Given this list of marker genes CBFA2T3, KCNE2 (NCBI Gene Id 9992), IL1B, NRDC, RACK1, MBP (NCBI Gene Id 4155), CSNK1E, PACSIN3, FADD, CYFIP2, ELOB, ASTL, RNF185, NKD2, FBXW8, PAQR3, DAB2, WFS1, BAG2, NUPR1, CLN6, FURIN, CDC20, GRN, DDA1, SIRT1, PLK1, SH3RF3, RCN3, SH3RF2, PABIR1, FBXW11, PSMC6, HSPA1A, PRICKLE1, VCP, CDK5RAP3, RHBDD1, SH3RF1, MDM2, IST1, PSMD10, F12, BAK1, ATP5IF1, DDRGK1, APP, FMR1, UBQLN2, TGFB1I1, LAPTM5, SEMG2, ATXN3, PSMC3, L3MBTL3, ASPH, ANGPTL8, AXIN2, HSPBP1, NFE2L2, TMTC3, SMAD7, SUMO2, MAPK9, SOCS5 (NCBI Gene Id 9655), UFL1, GBA1, TRIB1, PIAS1, CFL1, FBXO22, KLKB1, TRIM67, DET1, USP5, IL33, RFPL1, STUB1, RNF180, PRSS22, ECSCR, ZYG11B, TNP2, PSMC4, CLU, CAV1, ADRA2A, MYH9, HSPA1B, CASP8, TNFRSF1B, AURKA, TMX1, FBXW7, DISC1, PSMC1, SMURF1, PTEN, RNFT1, TMEM259, SOCS4, NUB1, RNFT2, RBX1, AKT1, PLGRKT, CSNK1D, XBP1, UBQLN1, SUMO1, FZR1, SH3D19, DVL1, MTOR, SRC, PLK3, BBS7 (Bardet-Biedl syndrome 7), HAMP, PSENEN, CEBPA, TNF, KLHL40, VSIR, PSMC2 (proteasome 26S subunit, ATPase 2), RNF139, CTSC, TBC1D10A, OGT, CAV3, USP13, ENO1, SPON1, SERPINB3, GABARAP, ANXA2, RCHY1, ADAM8, MELTF, AURKAIP1, PSMC5, TRIM32, PYHIN1, FGFR4, PRKN, IFNG, RGMA, TANK, BAG6, AXIN1, HPN, LRRK2, GPLD1, ZER1, ATXN3L, SIRT2, PRELID1, PSEN1, PERP, BAD, CDC20B, PTK2B, BCAP31, DAB2IP, SNX33, CHFR, TREM2, HERPUD1, CLEC3B, PTK2, CCBE1, APOE, NOP53, TNP1, SGTA, GSN, CAPN3, AGBL4, HECTD1, KEAP1, CSNK1A1, TRIB2, TRIB3, TF, ZFAND2A, GSK3A, SEMG1, BTRC, TRAF7, NLRC4, HDAC2, GSK3B, CR1, ADAM9, RAD23A, SIRT6, EGF, TAF1, MMP14, CCDC22, DNAJB2, GCLC, SNX9, AGTPBP1, S100A10, CNTN2, OSBPL7, COP1, IKBKG, NEURL3, here is a description of the gene set: Human Gene Set: GOBP_POSITIVE_REGULATION_OF_PROTEOLYSIS Any process that activates or increases the frequency, rate or extent of the hydrolysis of a peptide bond or bonds within a protein. species: Homo sapiens